Given this list of marker genes Ttc13, Phf21a, Ccl7, Zfta, Copz2, Cttnbp2nl, 1110006O24Rik, Hoxaas2, Dab2, Vegfa, Myo1e, Ankrd46, Ptpra, Sf3b5, Arhgap11a, Inpp1, Cux1 (NCBI Gene Id 384239), Pxn, Lrrc8c, Srr, Gm9996, Cep128, Cradd, Slc6a16, Gm15283, Fam185a, Ubap1, Tet2, Actrt3, Zfp260, Rny1, 1700095J07Rik, Atp6v0a2, Sfta2, Sanbr, 1700034P13Rik, Gcm2, Smndc1, Cdh19, Cep120, Rab5a, Cand2, Zmynd8, AI480526, Zfp710, Kdm2a, Heatr5b, Gm6225, Abcb7, Mir100hg, Depdc1a, Cd44, Bcl7a, Trarg1, Hoxa7, Cachd1, Pcdh7, Gpat3, Aanat, Kctd15, Gm11816, Selenop, Atf6, Irs1, G630016G05Rik, Mannr, Sdf2l1, Gm25308, Egr1, Ddr2, Ddi2, Gm18492, 2310043O21Rik, Id3, Apba3, Cep350, Gm13056, Rtcb, Ecpas, Gm5530, Abl1, Tut4, 1110038B12Rik, Chpf2, Epb41l3, Mzt2, Hoxa2, Scaf4, Tma16, Sart3, Kansl1, Rab33b, Ssc5d, Usp54, Hspa5, Ap1ar, Ifi204, Plau, Zfp148, Zfp768, Bloc1s6os, Fut7, Mindy3, Orc4, Smarcd3, Actr3, Slc38a6, Crtc2, Cdk14, Ifi211, Ptp4a2, Slc11a1, Pde4b, Atxn7l1, Med13l, Atp5mc1, Ermp1, Adamts6, Lztr1, Crlf3, Garin1b, Fli1, Slc29a1, Ppp1r12a, Gm5468, Psmb1, Fuom, Impdh1, Reps1, Shox2, Ccdc85b, Mirlet7i, Ranbp3, Gm10748, Ccdc122, Rin2, Zfp84, Sh3d19, Mir7091, Lrrc8d, Ppp6c, Pura, Tada1, Septin8, Nfkb1, Malsu1, Zswim3, Gtpbp6, Rab35 (RAB35, member RAS oncogene family), Armc7, Gnl2, Wls, Lmo4, Vim, AU015336, Nrn1, Slco2a1, Dgat2, Hdac10, Spp1, 2700033N17Rik, Gadd45b, Nrep, Prr13 (proline rich 13), Ccar1, Iscu, Cstb, Gm9991, Gm53, Plekha3, Diaph2, Psmc3, Rab36, 1700003E16Rik, Plekha8, Eif3f, Wdr36, 9430007M09Rik, Gm16008, Atosa, Mafg, Mir3083, 1700110C19Rik, Ppcdc, Zcchc9, Mx2, Srp68, Emp3 (epithelial membrane protein 3), Ccdc102a, Tmem116, Cox6c, Ccdc141, Stau2, Kank1, Cc2d1a, Gstm1, Rhd, Ssbp1, Nedd4, Pmpcb, Rftn2 (NCBI Gene Id 74013), Bloc1s1, Rnf141, Manba, Col6a3, Pfkl, Dmtf1, Adam17, Asb13, Rbms3, Sema3a, Zfp607b, Basp1, Rfx3, Ccn4, Alg9, Wipf2, Ep300, Fcf1, Taok1, Ocrl, Jpt2, Elac1, Blcap, F730043M19Rik, Dpf1, Magi3, Cnot6l, Rpl11, Gng5, Slc1a4, Kdm3a, Fzd4, Gm10441, Wdr7, Ifi27l2a, Gm4221, Acsl4, Ltbp1, Gas1, Fubp1, Naa20, Tsku, 1700013M08Rik, 4930449I04Rik, Tmem30a, Gstp1, Baz2b, Naa25, Itsn2, Msh5, Etv6, 2700069I18Rik, Rcan1, Ovca2, Tnrc18, Plaur, Dlx1, Pitpnc1, Mir152, Camkk1, Ndufaf5, Nudt4, Vps13c, 1810010H24Rik, Cap1, Trim29, Id4, Enho, Tgfb3, Por, Trav23, Egr2, Spaar, 2610035D17Rik, Gm12648, Dmap1, Myo19, Ccdc9b, Slc1a2, Jade2, Gdf11, Rapgef3os2, Phactr4, Pdzrn3, Dek, Fbxw7, Lrrn3, Abcb10, Ctnnd1, Fadd, Cdk15, Men1, Tm7sf3, Nr2f2, Zfp36l1, Exd2, Axl, 2610203C22Rik, Ghr, Mypop, Arl4aos, Exoc7, Lrrc4c, Edil3, Atn1, Rere, Tpcn2, Dnajb1, Mthfsd, Ensa, Nfix, Sin3a, Ldb2, Cab39, Gm10516, Gm31415, Pdk2, Kctd2, Efcab2, Thap2, Nt5m (5',3'-nucleotidase, mitochondrial), Gm11523, St13, Cdc20, Serf2, Cbx4, Ube2e3, Bzw1, Gm9939, Platr26, Zbtb20, Naa15, Rpl3l, Clcc1, Trabd2b (TraB domain containing 2B), Arhgef19, Tfap2a, Prrc2c, Emilin1, Txn1 (thioredoxin 1), Dnm1, Mir199a-1, 4932441J04Rik, Kirrel1, Sparc, Snupn, Slc25a40, Pbx2, Gm36017 (NCBI Gene Id 102639787), Gm15731, Zfhx4, Arhgap23, 9330179D12Rik, Tgtp1 (NCBI Gene Id 21822), Fitm2, Adck2, Rab3il1, Senp7, Nav3, Cic (capicua transcriptional repressor), Tuba1c, Mrgbp, Dap3, Ttc9c, Hoxd11, Gtf2b, Thop1, Nagpa, Runx2, Dnai2, Abi3, Aven, Tcf4, Kmt2c (NCBI Gene Id 384164), Meis2, Itih4, Dcakd, Spidr, Tax1bp1, Ociad2, Tcf12, Nfia, Ankub1 (ankyrin repeat and ubiquitin domain containing 1), Efemp1, Prrx1, Gpr85, Agpat1, Brme1, Pold4, Nr6a1 (nuclear receptor subfamily 6, group A, member 1), Gm11730, Clmp, Gata4, Ccdc80, Dusp5, Creb5, Lrrc7, Slc39a8, Rwdd2b, Arhgef1, C130023A14Rik, Rsad1, Rpusd4, Gm9929, Gm19085, Nipbl, Dtx4, Metap2, Zfp827, Ubtf, Gngt2, Colq, Gm42141, Hmox1, Gm19610, Mecom, Apod, Skida1, Fgfr1, Khdrbs1, Mir1903, Tbx2, Dpf2 (double PHD fingers 2), Dusp14, Cd63, Cd200, Gapvd1, Mir6974, Arl4a, Anln, Otx1, Mideas, Eri3, Eeig2, Ghdc, Mrpl48, Gsdma, Traj32, Slc39a14, Zfp462, Ap5s1, Cldn12, Gk5, AI606473, Samd1, Anxa1, Phf21b, Metrnl, Rxfp1, Eml4, Aebp2, Zcwpw1, Glipr1, Itpr3, Alms1, Hipk4, Asb8, Setd1b, Gcfc2, Krt16, Tgfbr3, Stbd1, Fosl2, Sik1, Erlin1, Smc1a, Klhl15, Etf1, Rbms2, Mbnl1, Zfp830, Dctpp1, Bin1, Spred2, Gm26744, Mettl6, Plekhg3, Plin4, Tmem79, Wfdc13 (NCBI Gene Id 408190), Gm4081, Pde3a, Snx7 (sorting nexin 7), Atp5pd, C1qtnf1, Flnc, Cr1l (NCBI Gene Id 12946), Nf1 (neurofibromin 1), Ebf1, Rcc2, Xxylt1, Foxf2, Sbk3, Pdlim2, Idnk, Apol8, Mrpl33, Zfc3h1, Maf, Meis1 (NCBI Gene Id 353058), Nectin1, Jsrp1, Celf1, Zc3h4, Sqstm1, Tex30, Mir125b-2, Hoxb6, Rsrc1, Gm11695, Vcpip1, Ybx3, Bahd1, Gm15927, Cox19, Ldb1, L3hypdh, Nrp1, Gramd4, Trnt1, Hoxc6, Setd6, Tenm4, Trpm4, Cfap68, Creg1, Rbm27, Gm6598, Hmgb1, Tnni3, Gphn, 4833413E03Rik, Gm12153, Ddr1, Cdc42ep5, Aif1l, Atad2b, Pros1, Nfib, Trib1, Mpp2, 4930429F24Rik, Gm9958, Gbp9, Utp3, Syncrip, Pigw, 1700001O22Rik, Pakap, Cyp3a13 (cytochrome P450, family 3, subfamily a, polypeptide 13), Gm12367, Med29, Zbtb45, Bcl6, Col27a1, A930033H14Rik, Has1, Zmynd11, Lacc1, Dlx1as, Gm12257, Ankrd35 (ankyrin repeat domain 35), Tab2, Snrnp48, Mgat4b, Adamts1, Gm13187, Tbx3, Taok2, Rgs16, Fubp3, Rheb, 1110025M09Rik, Sh3bp1, Ash2l, Fmo4, Clec3b, Gask1b, Zfhx3, Ammecr1, Cp, Cnih2, Plxna2, Hoxd3, Rbbp7, Mboat1, Ccnd2, Ercc1, Tmem135, Hsd17b7, Mir5135, Vax2os, Tns1, Yeats2, Yes1, Lox, Rtkn, E130114P18Rik, Marveld1, Lrig1, Usp14, 4930517L18Rik, Tbp, Dpm2, Higd2a, Lztfl1, Gm15860, Fbxo28, Parp11, Rasal2, Masp1, Strip1, Prr12, Me2, Sec61bl, Vgll4, Cox7a2l, Irag2, Trim16, Ddb2, Sphk1, Gata3, Jkamp, Zfp608, Lcorl, Gbp6, Icmt, Smad6, Fhl2, Hoxd4, Ripor3 (NCBI Gene Id 69553), Timm22, Ppp1r18os, Timp3, Arid1b, Gpr149, Ikbke, Mtrf1l, Islr, Ston2, Itpr1, Top2b, Eaf1, D430018E03Rik, Sox5, Opcml, Pcgf2, Gm16046, Mreg, Arrb1, Kpnb1, Clcf1, Cspg4b, Dnajc24, Mir7093, Lrrc27, Setd2, A330023F24Rik, Kank4os, Lix1l, Rhobtb1, Irag1, Mark4, Ppargc1b, Pcdh19, Gnas, 1700108F19Rik (RIKEN cDNA 1700108F19 gene), Elavl2, Anp32e, Hpf1, Rbm15, Meis3, Tbcc, Trim47, Tnks2, Card14, Slc16a5, Smim14, Emp2, 9930111J21Rik2, Tubb4b, Rnf5, Ankrd17 (NCBI Gene Id 81702), Arhgdib, Gm9694 (NCBI Gene Id 676894), Hs1bp3, Spata1, Rassf8, Vwf (Von Willebrand factor), Fgfr2, here is a description of the gene set: Genes containing one or more binding sites for (Zfp319) in their promoter regions (TSS -1000,+100 bp) as identified by GTRD version 20.06 ChIP-seq harmonization. Mouse Gene Set: ZFP319_TARGET_GENES studied in species Mus musculus from publication Yevshin I, Sharipov R, Kolmykov S, Kondrakhin Y, Kolpakov F (PMID 30445619)